Given this list of marker genes TLR2, SLIT1, NEUROD2, ROBO2, APOE, PGRMC1, ARHGEF15, NFATC4, WNT5A, PTPN13, DKK1, EPHA7, CLSTN3, CBLN1, here is a description of the gene set: Any process that stops, prevents or reduces the frequency, rate or extent of synapse organization. species: Homo sapiens Human Gene Set: GOBP_NEGATIVE_REGULATION_OF_SYNAPSE_ORGANIZATION